Given this list of marker genes Rhoa, Irs2, Ntrk1, Pik3cb, Pik3ca, Pik3r1, Ngf, Pik3r2, here is a description of the gene set: PI3K/AKT activation Mouse Gene Set: REACTOME_PI3K_AKT_ACTIVATION studied in species Mus musculus